Given this list of marker genes Tgfbr2, Cdk6, Casp8, Camk2d, Ccnd2 (cyclin D2), Id3, Jak2, Cbx4, here is a description of the gene set: Genes down-regulated in the induced pluripotent cells (iPS) and embryonic stem cells (ES) compared to the parental lineage-committed and partially reprogrammed cell lines. Mouse Gene Set: MIKKELSEN_PLURIPOTENT_STATE_DN studied in species Mus musculus from publication Mikkelsen TS, Hanna J, Zhang X, Ku M, Wernig M, Schorderet P, Bernstein BE, Jaenisch R, Lander ES, Meissner A (PMID 18509334) Somatic cells can be reprogrammed to a pluripotent state through the ectopic expression of defined transcription factors. Understanding the mechanism and kinetics of this transformation may shed light on the nature of developmental potency and suggest strategies with improved efficiency or safety. Here we report an integrative genomic analysis of reprogramming of mouse fibroblasts and B lymphocytes. Lineage-committed cells show a complex response to the ectopic expression involving induction of genes downstream of individual reprogramming factors. Fully reprogrammed cells show gene expression and epigenetic states that are highly similar to embryonic stem cells. In contrast, stable partially reprogrammed cell lines show reactivation of a distinctive subset of stem-cell-related genes, incomplete repression of lineage-specifying transcription factors, and DNA hypermethylation at pluripotency-related loci. These observations suggest that some cells may become trapped in partially reprogrammed states owing to incomplete repression of transcription factors, and that DNA de-methylation is an inefficient step in the transition to pluripotency. We demonstrate that RNA inhibition of transcription factors can facilitate reprogramming, and that treatment with DNA methyltransferase inhibitors can improve the overall efficiency of the reprogramming process.